Given this list of marker genes Arid5a, E030030I06Rik, Hddc2, Crocc, Pgbd1 (piggyBac transposable element derived 1), Casp8ap2 (caspase 8 associated protein 2), Rab18, 6530401F13Rik, Ebag9, Agtpbp1, Pih1d2, Duxf4, Hoxd3os1, Mir7222, Nr3c1, Rtbdn, Ctnnd2, Rps20, Gm14234, Aff4, Tpd52, Gm26047, Trmt13, Uggt2, Ctbp2, Gm6762, Rsrc1, Zfp783, Gls, Phf1, Bpifb1, Ccdc38, Spg7, Egln1, Ehd2, Pogz, Chst3, Gm10619, Copa, Stxbp1, Ncstn, Cep41, N4bp2l2, Lrpap1, Oasl1, Rps8 (ribosomal protein S8), Gm22972 (predicted gene, 22972), Pts, Tedc2, Zfp942, Taf8, Ahcyl2, Echdc2, Hells, Rasl12, Postn, Iqcm, Coro1a, Synj2bp, Trim23, Dner, Bud23, Gm26684, Anapc5, Pldi, Cops6, Ybx1-ps2, Zfa-ps, Dnaaf6, 4930412C18Rik, Rnf26, Isca1, Calu, Npl, Cntnap2, Dclk1, Ccl7, Ctc1, Clcn7, Aldh3a2, Fgd2, Layn, C030037F17Rik, Lmntd1, Twf2, Wdfy2, Tenm2, Ccdc181, Gm10419, Gtdc1, Rasl11a, Hcn2, Mcm8, Nav3, Sun1, Fstl5, Traj54, Plxnb2, Creb3, 1700120G11Rik, Ston2, Snord15a, H2-Eb2, Lhpp, Htatip2, Ncapd2, Mtmr3, Rhd, Rbis, 6230400D17Rik, Mcm3ap, Myo18a, Rsrc2, Smg8, Gm12109, Bbs2, Tead1, Akap17b, Adap1, Itih3, Lsm2, Gm3810, Sos2, Asap2, Gsdmc, Snord47, Cgref1, Gm26559, Mdm4, Snap47, Snapc4, Gm15622, Zkscan6, Gm10193, Pros1, Rbak, Krtap10-29, Rasl2-9, Rexo5, Gm13162, Krtap26-1, Sgms1, Osgin2, Usp21 (NCBI Gene Id 30941), Aloxe3, Cd6 (CD6 antigen), Lrrtm4, Fbxl8, Lrch3, Metap1, Cspg4b, Mettl5os, Prrc2a, Dcdc2b, Bptf, Arl6, Zfp646, Gm17101 (predicted gene 17101), Cacna2d4, Bltp1, Srrm2, Zmym1 (NCBI Gene Id 68310), Hectd2os, Pom121l12, Cldn4, Platr26, Gm23355, Srpk1, Gm15895, Kpna6, 1700046C09Rik, Ttc22, 5730405O15Rik, Mtcl1, Plac8, Bank1, Usp4, Gm15880, Mettl17, Carmil1, Lhx3, Cops5, 2900026A02Rik, Zfp113, 4930579K19Rik (NCBI Gene Id 75881), Ckmt1, Prox1os, Fah, Rhof, Dlc1, Chd6, Rmc1, Rab3gap1, Gstm7 (NCBI Gene Id 99761), Hcfc2, Kdm4b, Jmjd1c, 3110082I17Rik, Gm16191, Vsig10, Gm6543, Fam131b, Dpysl4, Ralgapa2, 2500004C02Rik, Tubgcp6, Prdm1, 4732463B04Rik, Adcy7, Dpy19l1, Trmt6, Ociad1, Rfesd, Gm38666, Vps51, Napa, Pphln1, Zfp867, 2610011E03Rik (RIKEN cDNA 2610011E03 gene), Zcrb1, Gm15179, Atg16l2, Dlgap5, Alad, Tex26, Usp46os2, Tmem62, Tbc1d22bos, Gas1, Gramd1a, Ninj1, Bdnf, Gm19872, Slco2a1, 1700027H10Rik, 4931419H13Rik, Cfap73, Lzts1, 4930447C04Rik, Socs2, 1110004F10Rik, 1810014B01Rik, Dram1, Dstyk, Preb, 4930505M18Rik, Klf3, Gm6361, Fgf4 (fibroblast growth factor 4), Rdh14, Nemp2, Mir7003, Gm13238, Gm7856, Ufd1, Tmem229b, 1700074A21Rik, Gm12411, Gm42875, Hnrnpf, C920006O11Rik, Gpr85, Zfp612, Traf3ip1, Zc3hc1, Zfp668, Gm10399, Gm26524, Otud6b, Ptgs2os, Cgrrf1 (cell growth regulator with ring finger domain 1), Snx7, Hapstr1, Mybl2, Pias3, Gm24336, Gldc, Cxcl5, Arb2a, Ppp1r16a, Strip2, Fbxw2, Tspan2, Gm2381, Large2, Vmn2r-ps26 (vomeronasal 2, receptor, pseudogene 26), Nsa2, Des, Slc25a1, Pde9a, 5330439A09Rik, Map1b, Gm26468, Rplp1rt, Cers3, Glp2r, Acat1, Anp32b-ps1, Elp2, Vmp1, Adamtsl5, Mphosph10, Oprk1, Itpa, Duxf1, Gm23339, Gm12712, Gjb4, E430021H15Rik, Ifnl3, Cnot7, Tcf25, Pex3, 5930411N13Rik, Pex2, Pold2, Eri2, Smg6, D830039M14Rik (NCBI Gene Id 320949), H2ac1, Lrrk2, C130046K22Rik, Batf3, Rab7b, Cfap74, Stard7, Ttll12, Fchsd1, Vps37a, Pik3ip1, Galk1, Tmem89, Aak1, 4933405D12Rik, Myof, Atf7ip, Mir3062, Nsf, Dxo, Rps19-ps5, Dnajc24, Zfp82, Col8a2, Smarca5-ps, Cyp7b1, Dnai3, Dmrt1, Sidt2 (NCBI Gene Id 214598), Vwde, Lipa, Tln1, Tmem61, Traf3ip3, Trak1, Hsd17b14, Parp1, Fer1l6, Gm16853, Dpp7, Abcc10, Anks1b, Krt81, Galnt13, Matk (megakaryocyte-associated tyrosine kinase), Gm12707, Tufm, Thsd1, Fbf1, Gm7452, 1700065D16Rik, Anapc4, Vps45, Sntg1, Eeig2, Fkbp14, Gm7862, AI661453, Srgap3, Ece2, Zfp787, Ptges3, Yae1d1, Noxa1, A630050E04Rik, Csnk1g1, Gtpbp2, Zdhhc24, Stau2, Cd81, Fcsk, Cda, Csgalnact2, Zmym5, Magi3, Fer1l4, Brms1l, Myo1f, Pou2f1, Pla2g6, Gm12063, Frmd4b, Recql, Phf13, Hs3st2, Cdk11b, Psd2, Nfatc2, Trmt112-ps2, Vwa5b1, Adgre5, Commd3, Gm13490, Klc1, Bmp7, Gcnt7, Gm5067, 4930519G04Rik, Lhx9, Acox1, Mir185, Dmrt2, Krtap4-24, E130304I02Rik, Zfp61, Zbtb45, Il6st, Fkbp3, Tmcc1, Rpusd4, Dhx29, Sumf2, Shank1, Gm13267, Gatm, Xrn1, Cfap43, Ccnt1, Gimap1, Fam98c, Ear6 (NCBI Gene Id 93719), Cherp (NCBI Gene Id 70519), Gm15371, Gm27216, Zbtb7b, Abra, Tut4, Phyhd1, Clk2, Zfp120, Atp5po, D930032P07Rik, Fli1, Ift22, Synpo, Me2, Mical1, Lpar1, Gpt2, Pkia, Gm13241, Mknk1, Tmem14a, Gm12045, Ankef1, Tpm1, Slc30a2, Ccz1 (CCZ1 vacuolar protein trafficking and biogenesis associated), Topbp1, Bmf, Map3k7, Ubxn2b, Aldh1a3, Sdhaf4, Nfkb1, Fbxo11, Dnah14, Timm8a2, Gpld1 (glycosylphosphatidylinositol specific phospholipase D1), Zfp637, Vezf1, Tmem177, Gm30003, Sct, Scube1, Gm34379, Syce2, Rbm43, Ankle2, Gm42707, Itgbl1, 1700092C17Rik, Tm2d1, Eln, Nme7, Ly6e, Slc2a12, Atg7, Pnpla7, Pde4d, Fanca, Tle2 (transducin-like enhancer of split 2), Wdr62, Alpi, Zfp383, Rbm5, Zdhhc23 (zinc finger, DHHC domain containing 23), Krt87, Sco1, Myo10, Nsun5, Gm13549, Meis1, Gm13359, Snrpg, Slc17a6, Cacna1h, Rad51ap2, Stk19, Wsb2-ps, Ddx1, Ppil1, Zkscan5, Gm14250, Pptc7, Ric1, 1700012J22Rik, Kank3, Pdhb, Chaer1, Rpl21 (NCBI Gene Id 66814), Myo3a, Zfp866, Gm17214, Prcd, Gm10045, Smim14, Tmem219, Ube2l6, Actn3, Pcbp3, Mdm2, Cwc22, Zfp26, Gm26911, Gm13034, Rassf8, Mcm10, Slitrk5, Mrps7, Appl2, Cic, Dnmt3a, Med13l, Mtarc2, Gm6633, Acta2 (NCBI Gene Id 68377), Grep1, Kcnab2, Plcb1, Kcnb1, St7, Zfp454, Ccdc152, Obsl1, Myo1b, Psmd14, Ido1, Tbc1d9, Ash2l, Mars1 (methionine-tRNA synthetase 1), Gm29856, Gdpd4, Arap2, Cd55, Mrpl23, Mir6923, Spsb2, Gfra1, Rb1cc1, Calhm2, Ppp1r16b, Hsf4, Armc6, Vangl2, Thsd4, Hjurp, 2610005L07Rik, Tnrc18, Tsen54, Hectd3 (NCBI Gene Id 76608), Gm5898, Car13, Etaa1os, Dop1b, Zswim9, Rida, B430212C06Rik, Dnal4, Dusp11, Disp1, 2810432F15Rik, Dtx3, Rps12-ps19, Dync1h1, Wbp11, Hhatl, Rusc1, Kntc1, Ltbp4, Snord90, Dpysl5, Car11, Ptbp3, D430041D05Rik, Mir6339 (NCBI Gene Id 102466628), Gm12301, Dusp2, Syk, Tnr, Vps50, Fpgs, Nubp1, Gm12017, Lztfl1, Ncdn, Sla, Ugp2, Mei4 (NCBI Gene Id 75033), Nt5dc1, Gm11424, Megf8, Gm7977, Ndst3, Aph1c, Ube2d-ps, 2610016A17Rik, Tfam, Cnga3, Fam98b, Inhca, Tsn, S2bpcox16, Map2k2, Rpl17-ps9, Chmp3, Ptpn9, Dmpk, A330094K24Rik, Mroh8, Sppl2a, Rhobtb1, Cnn1, Kat6b, A330041J22Rik, Ccdc137, Nr5a1os, Cyp2j6, Dlat, Gtf2h4, Gm6994, Pbx2, Fgfr1 (NCBI Gene Id 14182), Cops7b, Tpst2 (protein-tyrosine sulfotransferase 2), Jak2, Homer2, Cthrc1, Anp32e, Zscan5b, Tmem140, Igf2, Tor1aip1, Hmgn2, Dgki, Accsl, Cyp2r1, Dst, Cdk5rap2, Hacd4 (NCBI Gene Id 66775), Gm24016 (NCBI Gene Id 115490074), Vegfc, Nav2, Pask, BC049715, Palm3, Arhgap31, Kif13b, Tmem132b, Dusp13b, Snhg5, Neurod6, Mrpl42, D830013O20Rik, Gmds, Snord55, Stk3, Gm24457, Pxylp1, Plekhg5, Gpaa1, Med28, Ncor1, Tlx1, P2rx2, Rusc2, Map2, Cib2, Gne, Maoa, Ube3d, Mtrf1l, Scg3, 4930544I03Rik, Ranbp1, Kdm4a, Gm18800, Slc19a1, Cox5b-ps, Inpp4a, Ddx27, Erich5, Lrrc28, Calcoco1, Tnfrsf13b, Bmpr1b, Gm7936, Dab2ip, Heyl, Mgat4c, Gm27449, Ppp5c, 4933427D14Rik, Gm26330, Ythdf1, Ndufs3, B3gnt9, AW047730, Ncald, P3h1, Filip1, AA387200, Sult2b1, Plec, Mpzl1, Cntrl, Ppp1cb, Cyb561a3, Rnf212, Cilk1, Ddx46, Nphs1, 4833413E03Rik, Ddx60, Rora, Rnf166, H2az2, Dgat2 (NCBI Gene Id 67800), Vdac1, Klrh1, Prim2, Smim24, Eif1b, Paf1, Dab1, Prox1, D130043K22Rik, Mindy1, Pdp1, Tcf4, Lce1j, Basp1, Rpl7a-ps9, Rhbdd3, Afdn, Mtch1, Snord99, Svil, Adamtsl4, Ndfip2, Gm37047, Copg1, Naalad2, Prima1, Map3k1, Rpl5, Gm20257, Tm4sf5, Rdm1, Fndc7, Coq8a, Anapc10, Fetub (fetuin beta), Gm25744, Ipo8, Dnajc30, Spag1, Nckap5los, Krba1, Rabgap1l, Gm16573, Dph1, Gm33474, Dapl1, Arhgap20os, C1galt1, Alg3, Nagpa, Ttc14, Pde4b, Mrpl27-ps, Cux1, A730004F24Rik (NCBI Gene Id 320449), Smchd1, 1700003G18Rik, Lrrc4, AW209491, Pdhx, Mir493, Hecw2, AK157302, Lpcat3, 1700017G19Rik, Bud13, Keap1, Furin, Rapgef1, Kazald1, Osbpl9, Npr2, Mns1, Celsr1, Tmco1, Tars2, Ttll10, Mnd1, Sptan1, Sema6c, Dsp, Nnmt, Elk4, Gm7457, Gm13816, Slc38a3, Rpl18a-ps1, Smim1, Mrpl32, Slc26a5, Pdzd7, Slitrk3, Myl7, Cfap251, Brd1, Zfp652 (NCBI Gene Id 544673), Ddt, Pnisr, Acoxl, Slc35b1, Pms1, Clcc1, Kif24, Txn2, Pou6f1, Hepacam2, Syt11, Eya4, D230022J07Rik (NCBI Gene Id 320471), Ilf2, Gm9727, Lrit3, Tmem217rt, Art5, Gm7104, Med29, Pnkp, Il9r, Tcf7l2, Bet1, Fbxo31, Gstt3, Spr-ps1, Zfp68, Tnni3, Kpna2-ps, St3gal5, Mrpl15, Oplah, Ubr1, Ice1, Tgif2-ps2, Fam114a2, Gm5867, Phrf1, Gm22830, Dap, Lig3, Ccdc186, Gm13689, Ace, Gm12904, Gm12955 (predicted gene 12955), Itpkc, Gm20940, Timp3, Gprasp1, Sfi1, C030017D09Rik, Aff3, Ctdsp2, Prox2, Ciapin1, Mettl5, Nup210, 1110038B12Rik, Inpp5e, Rpl3, Dscaml1, Trpc2, Fbxw10, Il10ra, Ssbp1, Sqstm1, Prkcz, Ufl1, Arfrp1, Hmox1 (NCBI Gene Id 27970), Nup62cl, Sgms1os1, Cr1l (complement C3b/C4b receptor 1 like), Rnf20, Trpm1, Gm3436, Sst, Mir7677, Ift46, Nup42, Acss3, Trpm5, Rptor, Cep128 (NCBI Gene Id 75216), Zfyve1, 4930578M01Rik, Ppp1r21, Pum2, Vars2, Cfap298, Coro6, Fgf18, Lasp1, Mecomos, Sptbn5, Trmt2a, Gm15510, Phactr2 (phosphatase and actin regulator 2), Gm16547, 9130604C24Rik, Nos1, Mir7654 (NCBI Gene Id 102465762), Onecut1, Fbp1, Ubqln4, Rnf114, Zfp799, Gng7, Dnajc19, Lgals3bp, Tmem237, Ccnd1, Amdhd1 (amidohydrolase domain containing 1), Ccna1, Psmd12, Gm25290, Deup1, Gm26512, Gm12475, Gm14269, Npdc1, Il21, Zfp648, Ctsc, Apod, Eps8, Pak2, Robo3, Dnaaf9 (NCBI Gene Id 98941), Pex11a, Foxr1, Mfap3, Ghdc, Dnajc15, Pcdh1, Ptpn23, Insc, Tapt1, Ankrd39, Cd200, Gm25829, Nek11, Exosc3, Gm16794, Gm5278, Gm19148, L3mbtl1, Eif3b, Gm15736, Sppl3, Ppm1n, Abhd17a, Ttyh1, Dot1l, Ankrd42, Msl3l2, Syt12, Ugt1a10, Fam81a, Metap1d, Bnip2, Cenpt, Gm26097, Fgfr2, Tlk1, Timm21, Gpr160, Cenpu, Trip4, Msantd7, Pfas, Cul2, Altre, Tnfaip1, Gm6871, Gm15785, Gm10501, Capn10, H3f3b, Ormdl1, Gm43001, Kcnq2, Sulf2, Stk11ip, Gm7324 (predicted gene 7324), Rab44, Arhgap32, Gm29514, Ino80b, Sirpa, Gm15340, Katnal1, Syt8, P2ry14, Atg4c, Gpr142, Coro1c, Cfap161, Lhfpl6, Golim4, Ap1s1, Ppp2r1b, Herc2, Ptpn18, Gm26202, 1700028K03Rik, Azin2, Idua, Exo1, Gm13019, Dazap2, Mettl25b, Nup35, Cibar1, Rnmt, Tnfaip8l3, Lrp5, H4c4, Lgals4, Mecom, Plet1, Sys1, Ghrh, Alg1 (NCBI Gene Id 208211), Synj2, 1700010K24Rik, Spata7 (spermatogenesis associated 7), 1700092E19Rik, Cpeb3, Zbtb7c, Nfatc1, Niban2, Gstp1, 2610306M01Rik, Tradd, Ak4, Tcl1b2, Pcdhga7, Nubpl, Ube3a, Syncrip, Gm13370, Piwil1, Agrp, Dsc1, Epx, Med23, Spata2l, Gm13880 (predicted gene 13880), Clec4b1 (NCBI Gene Id 69810), Mfge8 (milk fat globule EGF and factor V/VIII domain containing), Ccdc171, Nup214, Arsg, Nfia, Mrps36, Gm4248, Gm33866, Lin7b, Phox2a, Taf10, Idh3a, Spice1, Asap1, Speg, Cfap299, Dzip1l, 5730420D15Rik, Slc13a4 (solute carrier family 13 (sodium/sulfate symporters), member 4), 1810062O18Rik, Gm26654, Grem2, Filip1l, Slc22a15, Pstpip1, Safb, Panx3 (pannexin 3), Fbh1, Pabpc4, Xylt2, 5730522E02Rik, Mir3078, Ndufc2, Sp2, Psma5, Slc6a21, Spats1, Hkdc1, C2cd3, Pik3cg, Gm7417, Copb2, Abcg2, Meis2, Gm12865, Mif4gd, Aph1b, Mmp19, Eif4g1, Itm2b, Serpinb6d, Gm10101, Smc2os, Vps39, Agrn, Zmynd15, Gm15983, Serpine2, Agbl4, 1700096K18Rik, Zfp87, Pik3cb, Gspt2, Cxcl16, Coq8b, Cd5, Ppip5k2, Iqce, Fez2, Gm6872, Dapp1, Brd2, Zfp940, Mir7235, Gtf2ird1, Rasgrp3, Mybpc2, Hspe1-ps5, Oxld1, Zfp184, Cspp1, Cdc42bpg, Ppp4r1, Gm14248, Rabgap1, 1110018N20Rik, Mylk4, 4930558J18Rik, Ttc23l, Traf5, Fat1, Nrxn1, Rbbp6, 1700010L04Rik, Gm14127, Tmbim6, Manba, Gm14213, 2010315B03Rik (NCBI Gene Id 72071), Dyrk1b, Adamts6 (ADAM metallopeptidase with thrombospondin type 1 motif 6), Rhoc, Bcat2, Cimip2a, Rnasek, Vamp2, Gm11212, Akap10, Abhd12b, Grb7, Aicda, Gm16167, Cfap97d1, Rpn2, Ikzf3, A830082K12Rik, Agps, Gm24668, Txnrd2, Lvrn, Scp2, Cdnf, Ptprv, Crbn, Ceacam19, Dhx37, Zc3h7a, Tbc1d9b, Tubd1, Nt5el, Ssc4d, Atp6v0b, Bub1b, Trim68, Nek3, Adam3, Ddr1, Serinc1, Snord42b, Cflar, Spag6l, Bicra, Il34, Ivd, Sec61a2, Nup85, Syt4, Mctp1, Olfm4, Rab11b, Rnf168, Zfp975, 2700049A03Rik, Eif2b4, Gm13369, Lbp (lipopolysaccharide binding protein), Mcee, Btg3, 2010103J01Rik, Has2os, Mbp, Rpl23a, Nexn, Rab3gap2, Smarcd2, Gins1, Gm13822, Ubxn10, Secisbp2l, Heatr5b, Sgk2, Htt, Gm11401, Slc17a8, Tmem117, Acads, Nr1i3, Gm13203, 1700030N18Rik, Zdhhc7, Chac2, Rrbp1, Gm15715, Arrb2, Tmem132e, Elavl2, Gm13657, 9030622O22Rik, Slc39a6, Stoml1, Slc18b1, Gm6141, Mdp1, Lyl1, AU022252, Gm12420, Pag1, Chchd1, Rps19bp1, Sptlc1, Gm14383, 2810021J22Rik, Cacng4, Myb, Pex7, Pdss1, H2bc26, Mcc (mutated in colorectal cancers), Lag3 (lymphocyte-activation gene 3), Cdv3-ps, Ptcra, Crispld2, Gm10537, Dusp4, Gm15286, Prmt7, Zfp266, Gm10837, Dhodh (NCBI Gene Id 75427), Mir6236, Cyp4x1, Lyg1, Zfp105, Fam241a, Mrps21, Jak3, Accs, Gm16083, Sh2d6, Ptar1, Bcas1, Gpa33, Mir132, Tekt3, Msrb3, Apip, D630008O14Rik, Mir9-2hg, Plekhb1, B230303O12Rik, Wfdc3, Zfp982, Wdpcp (WD repeat containing planar cell polarity effector), Sft2d1, Xbp1, Gm16023, Ftl1-ps2, Dio1, Spink2, Snord83b, Gm7933, Mir8116, Rhno1, Gpr83, Cidea, Tango2, Gm20404, Fkbp8, Stard3nl (STARD3 N-terminal like), Fn3krp, Srp72, Traj53, Dmxl1, Chrna4, Gm8508, Gm5046, 1810008I18Rik, Arfgap2, Fam43b, Lrrc52 (NCBI Gene Id 76868), Nudt17, Gga3, Gm36070, Asnsd1, Ccdc68, Ssbp3, Aldh1l2, Nrg2, BC031181, Appbp2os, Adam32, Abce1, 1810037I17Rik, 1110035H17Rik, Kpnb1, Zfp560, Mideas, Kmt2c, Ten1, Sema5b, Pfkp, Ube2m, Plcb4, Coasy, Gpatch4, Ido2, Gm20760, BB031773, 2210016L21Rik, Cfap61, Fbxo6, Zcchc14, Gm7832, Gtsf1, Hacl1, Tmem208, Hps3 (NCBI Gene Id 12807), Tmem132c, Ahr (aryl-hydrocarbon receptor), Shroom3, Gm6044, Adamts20, Sp140l2, Akap7, Bola2, Lrrc46, Cpxm1, Tuba8, Gm12221, Ncaph, Abcf2, Nr5a1 (nuclear receptor subfamily 5, group A, member 1), Prune1, Rab12, Smok2a, Cryzl2, Csdc2 (NCBI Gene Id 223704), Ggta1, Doc2a, Mtrex, Gas2l2, Gm13146, Ddx4, Fbxo9, Mtarc1, Samd8, Fmnl1, Creld1, Slc22a20, P4ha3, Itih4, Gm13240, Marchf8, Cyb5rl (cytochrome b5 reductase-like), Aste1, Enah, Gm13430, Smim19, 4930477E14Rik, 2010003K11Rik, Kbtbd4 (NCBI Gene Id 67136), Cyb5r1, Ankrd16, Ccdc50, Vmn2r-ps16, Plcl1, Anln, Epn2 (NCBI Gene Id 78669), Ctse, Dcdc5, Atp10d, Gm13431, 5730455P16Rik, Rpf1, Fn1, Ptgs2, Galk2, Gm29257, Gm9887 (predicted gene 9887), AU040320, Lypla1 (lysophospholipase 1), Ubr4, Gm25789, Tmbim4, Gm10653, Ccdc50-ps, Faap100 (NCBI Gene Id 71885), Pdcd2l, Bok, Ano4, Gm12218, Acat2, Synpo2, Paqr3, Dync2h1, Gem (GTP binding protein overexpressed in skeletal muscle), Gm26416, Fam13a, Colq, Flt4, Dgcr6, Ahctf1, Snx17, Pakap, Lig1, Ank1, Atrnl1, Smco2, Pex5l, Gm5914, Gm25259, D5Ertd579e, Sass6, Cd300a (CD300A molecule), Tcof1, Ino80dos, Dlgap2, Gm12957, 1700001G17Rik, Pilrb2, Gm21963, Ccdc190, Hk1, 2900092N22Rik, Gm23897, Xpr1, Aff1, Tulp3, Minar1, Gm1604a, Naf1, Gm11837, Tmem260, Tma16, Fbln1, Cln6, Stk36, S100a8, Osbpl1a, Rtel1, Nhp2, Mir8098 (microRNA 8098), Gm24840, Slc6a12, here is a description of the gene set: Genes containing one or more binding sites for (Spen) in their promoter regions (TSS -1000,+100 bp) as identified by GTRD version 20.06 ChIP-seq harmonization. Mouse Gene Set: SPEN_TARGET_GENES species: Mus musculus from publication Yevshin I, Sharipov R, Kolmykov S, Kondrakhin Y, Kolpakov F (PMID 30445619)